The following is a description of a gene set: studied in species Homo sapiens Human Gene Set: GOBP_MAMMARY_GLAND_DUCT_MORPHOGENESIS The process in which anatomical structures of the mammary ducts are generated and organized. Mammary ducts are epithelial tubes that transport milk., and this is the list of marker genes: WNT4, PHB2, FGF10, PTCH1, NR3C1, CCL11, ETV5, TGFB1, TFAP2C, DDR1 (discoidin domain receptor tyrosine kinase 1), CSF1, AREG, WNT5A, KDM5B, SOSTDC1, VDR, AR, CAV3, MSX2 (NCBI Gene Id 8053), ESR1, PML, PERP, CSF1R, FGFR2, EPHA2, SCRIB, PGR, NTN1, CSMD1, MED1, LRP5, SRC, BTRC, TBX3